Given this list of marker genes Mat1a, Txnrd1, Sephs2, here is a description of the gene set: studied in species Mus musculus electronically inferred by orthology from the curated human pathway part of: Metabolism of amino acids and derivatives This event has been computationally inferred from an event that has been demonstrated in another species.<p>The inference is based on the homology mapping from PANTHER. Briefly, reactions for which all involved PhysicalEntities (in input, output and catalyst) have a mapped orthologue/paralogue (for complexes at least 75% of components must have a mapping) are inferred to the other species. Reactome Pathway: Selenoamino acid metabolism